Given this list of marker genes CHMP7 (NCBI Gene Id 91782, charged multivesicular body protein 7), HSPA8, CHMP2A, PLIN3, RPS27A, MVB12A, VPS28, UBB, VPS37D, UBAP1, CFTR, HDAC6, VIM, ARL13B, CHMP4B, PLIN2, VPS37C, IFT88, PCNT, CHMP2B, HBB (hemoglobin subunit beta), UBA52, PARK7, CHMP4A, VPS37A, CETN1, CHMP4C (NCBI Gene Id 92421), MVB12B, CHMP3, RNASE1, UBC, CHMP6, VPS37B, TSG101, here is a description of the gene set: Human Gene Set: REACTOME_LATE_ENDOSOMAL_MICROAUTOPHAGY species: Homo sapiens Late endosomal microautophagy